Given this list of marker genes Slc2a4 (NCBI Gene Id 20528), Lipc, Abca9, Slc24a2, Slc39a14, Ireb2, Slc16a8, Abcb5 (ATP-binding cassette, sub-family B member 5), Prkaca (protein kinase, cAMP dependent, catalytic, alpha), Atp4b, Trf, Abcb9, Ano10, Atp6v0d1, Rps27a, Slc36a2, Psmd12, Angptl4, Slc35b2 (solute carrier family 35, member B2), Csn3, Slc39a2, Slc17a1, Atp8a1, Steap3, Slc12a5, Slc8b1, Ahcyl2, Smdt1, Apoa1, Slc38a2, Atp9a, Abca12, Add1, Asic3, Atp2a3, Trpm4, Slc14a2, Atp2b3, Slc25a4, Csn1s1, Slc26a1, Trdn, Gng10, Abcd2, Slc47a1, Atp1a2, Car4, Apoc3, Psmb4, Slc30a10, Atp7b, Mrs2, Slc9a1, Apoc4, Slc26a9 (solute carrier family 26, member 9), Slc24a5, Gnb2, Slc3a2, Slc7a6, Slc25a11, Psmd7, Clca1 (chloride channel accessory 1), Slco4c1, Atp6v1d, Ano2 (NCBI Gene Id 243634), Atp6ap1 (NCBI Gene Id 54411), Plekha8, Slco1c1, Apoa2, Pdzd11, Ubb, Mcub, Slc2a12, Psma2, Abcc10, Tusc3, Abcg5, Apobr, Tfr2, Calm1, Ryr1, Abcd1, Atp8b1, Abcb8, Abcc4, Abca1 (NCBI Gene Id 11303), Bmp1, Clcn4, Atp6v1g2, Mlkl, Atp6v1c2, Ctns, Fbxl5, Lmf1, Slc6a7, Slc26a11, Scnn1b, Slc5a8, Slc13a2, Ano8, Abcg2, Asic5, Mip, Phb2, Lpl, Tcirg1, Atp9b (NCBI Gene Id 50771), Slc22a1, Pln, Apoa5, Atp4a (ATPase, H+/K+ exchanging, gastric, alpha polypeptide), Slc4a2, Slc13a4, Lcn9, Slc39a7, Slc9a5, Fxyd2, Slc17a3, Nipal4, Slc5a9, Cln3, Psma5, Psmb6, Atp6v0e2, Atp13a5, Tsc22d3, Atp8a2, Ces3b, P4hb, Gng8, Ftmt, Lrrc8c, Apoe, Ngb, Atp11b (NCBI Gene Id 76295), Psmb7, Trpc7, Esyt1, Azgp1, Slc22a3, Fth1, Micu1, Slc36a4, Ttyh3, Aqp8, Slc4a9, Asic1, Psma6, Slc22a16, Fgf21, Tpcn2, Clca4b, Slc11a2, Cul1, Aqp1, Derl1, Camk2b, Aqp7, Fkbp1b, Apob, Psmd13, Slc1a4, Slc26a4, Slc22a12, Avp, Slc25a18 (NCBI Gene Id 71803), Aqp12, Gng4, Best3, Ces3a, Eif2s3x, Slc5a4a, Dmtn, Mcoln1, Alb, Hbb-bt, Slc6a1, Psmd6, Slc9b2, Slc4a1, Trpm8, Sel1l, Phb1, Atp6v0c, Asic4, Atp6v0e, Atp1b3, Prkacb, Atp6v0a4 (NCBI Gene Id 140494), A2m, Atp8b2, Ano7, Atp6v1f, Aqp5, Slc5a7, Slc12a2, Slc41a2, Rab11fip2, Slc44a4, Stoml3, Gpihbp1, Gng3, Slc4a10, Clcn6, Atp6v1g3, Slc25a5, Best1, Slc22a6, Apoc1, Nipal1, Atp6v0a1, Slc25a22, Psmc3, Slc44a2, Psmc2, Gng7, Abcb6, Best2, Psmc6, Slc30a5, Vcp, Prkar1b, Pex19, Slc22a5, Pip, Slc13a1, Slc15a1, Slc12a4, Slc13a3, Psma1, Slc5a3, Slc17a7, Slc16a10, Psmc1, Slc7a8, Trpm6, Lipa, Slc5a6, Slco1a4, Slc2a13, Aqp4, Kcnj11 (potassium inwardly rectifying channel, subfamily J, member 11), Abcg8, Ano5, Rhcg, Npc2, Abca7, Bsg, Slc20a2, Hmox2, Slc24a3, Ap2s1, Apoc2, Slc44a3, Sgk1, Gng11 (NCBI Gene Id 66066), Trpc5, Vldlr, Slc11a1, Aqp11, Abcg1, Slc6a3, Atp13a1, Abcc2, Arf1, Cybrd1, Atp2a1, Scnn1g, Abca6, Abcc3, Mfsd4b4, Gngt1, Abcb4, Slc38a3, Clcnkb, Rab11a, Pcsk5, Unc79, Casq1, Slc6a9, Atp12a, Nek4, Slc66a1, Gngt2, Fxyd3, Trpv2, Slc7a10, Erlec1, Slc6a13, Slc6a19, Scnn1a, Trpa1, Abca5, Slc28a1, Slc17a8, Lcn12, Atp13a2, Psmc4, Slc26a6, Avpr2, Gnb5, Abcb7, Nipal3, Apoa4, Psma4, Apod, Atp2b1, Rhbg, Slc7a3, Slc35d1, Atp6v1e2, Trpc1, Slc9a6, Ap2b1 (adaptor-related protein complex 2, beta 1 subunit), Slc41a1, Slc25a10, Slc24a1, Slc5a2 (solute carrier family 5 (sodium/glucose cotransporter), member 2), Atp2b4, Slc30a8, Slc7a9, Ap2a1, Slc35d2, Atp6v1a, Trpc4ap, Psmc5, Slc22a18 (solute carrier family 22 (organic cation transporter), member 18), Gng5, Slc29a3 (solute carrier family 29 (nucleoside transporters), member 3), Atp1a3 (NCBI Gene Id 232975), Slc39a6, Ap2m1, Slc6a2, Nalcn, Slc26a7, Trpv6, Gnb3, Slc4a4, Angptl3 (NCBI Gene Id 30924), Nedd8, Abca8b, Ano9, Ano4, Cyb5r2, Slc2a1, Slc16a3 (solute carrier family 16 (monocarboxylic acid transporters), member 3), Slc29a2, Trpv5, Slc50a1, Afg3l2, Slc39a4, Pmpcb, Slc4a8, Hfe, Slc22a8 (NCBI Gene Id 19879), Trpc6, Slc1a6, Slc26a2, Cptp, Slc15a3, Yme1l1, Atp1b2, Micu3, Ldlr, Stoml2, Slc1a7, Psmb5, Derl3, Slc22a2, Atp1b1 (ATPase, Na+/K+ transporting, beta 1 polypeptide), Slc2a8, Slc7a7, Slc2a6, Slc3a1, Slc12a3 (solute carrier family 12, member 3), Slc27a1, Aco1, Psmd1, Psma3, Slc27a6, Slc35c1, Nceh1, Prkar2b, Trpm5, Pltp, Psma7, Atp2c2, here is a description of the gene set: electronically inferred by orthology from the curated human pathway This event has been computationally inferred from an event that has been demonstrated in another species.<p>The inference is based on the homology mapping from PANTHER. Briefly, reactions for which all involved PhysicalEntities (in input, output and catalyst) have a mapped orthologue/paralogue (for complexes at least 75% of components must have a mapping) are inferred to the other species. Reactome Pathway: Transport of small molecules studied in species Mus musculus